The following is a description of a gene set: Mouse Gene Set: GOBP_PORPHYRIN_CONTAINING_COMPOUND_METABOLIC_PROCESS The chemical reactions and pathways involving any member of a large group of derivatives or analogs of porphyrin. Porphyrins consists of a ring of four pyrrole nuclei linked each to the next at their alpha positions through a methine group. species: Mus musculus, and this is the list of marker genes: Srrd, Bdh2, Abcb10, Ank1, Cyp1a2, Cox10, Cox15, Cyb5r4, Rsad1, Fech, Blvra, Uros, Slc11a2, Alad, Tmem14c, Pgrmc1, Slco1b2, Abcb6, Tmem14a, Snx3, Cpox, Alas1, Slc6a9, Sptb, Slc25a39, Hmox2, Ugt1a1, Abcb7, Cyp1a1, Eif2ak1, Ppox, Urod, Alas2, Hpx, Slc48a1, Hnf1a, Blvrb, Cyp2a5, Spta1, Hebp1, Hmox1, Slco1a6, Ireb2, Fxn, Iba57, Atp5if1, Hmbs